Given this list of marker genes SLC6A2, here is a description of the gene set: part of: SLC transporter disorders species: Homo sapiens SLC6A2 encodes the sodium-dependent noradrenaline transporter NAT1 which terminates the action of the neurotransmitter noradrenaline by transporting it from the synapse back to its vesicles for storage and reuse (Broer & Gether 2012, Schweikhard & Ziegler 2012). SLC6A2 is expressed in the CNS and adrenal glands. Defects in SLC6A2 can cause orthostatic intolerance (OI; MIM:604715), a syndrome characterised by lightheadedness, fatigue and development of symptoms during upright standing, relieved by sitting back down again. Plasma norepinephrine concentration is abnormally high (Lambert & Lambert 2014). Reactome Pathway: Defective SLC6A2 causes orthostatic intolerance (OI)